Given this list of marker genes nef, vif, gag, gag-pol, rev, vpu, PPIA, vpr, here is a description of the gene set: part of: Early Phase of HIV Life Cycle studied in species Homo sapiens Reactome Pathway: Uncoating of the HIV Virion HIV-1 uncoating is a poorly understood process. It likely involves a progressive and partial dissembly of matrix and capsid layers. While viral proteins like MA and Nef are thought to be involved, the primary cause seems to be the cytosolic pH and a simple dilution effect. Successful uncoating generates the viral reverse transcription complex, which comprises the diploid viral RNA genome, tRNALys primer, RT, IN, MA, nucleocapsid (NC), viral protein R (Vpr) and various host proteins; the reverse-transcription complex is thus liberated from the plasma membrane. It is believed that the transiting viral nucleoprotein complex associates with the elements of cytoskeleton like actin microfilaments.